The following is a description of a gene set: Mouse Gene Set: CUI_T_CELL_GD_IL1A_RESPONSE_UP studied in species Mus musculus Genes positively differentially expressed in cell type: γδ T cell upon treatment with cytokine: IL-1α in mouse lymph nodes in vivo. Cytokines mediate cell-cell communication in the immune system and represent important therapeutic targets. A myriad of studies have highlighted their central role in immune function, yet we lack a global view of the cellular responses of each immune cell type to each cytokine. To address this gap, the authors created the Immune Dictionary, a compendium of single-cell transcriptomic profiles of more than 17 immune cell types in response to each of 86 cytokines (>1,400 cytokine-cell type combinations) in mouse lymph nodes in vivo. A cytokine-centric view of the dictionary revealed that most cytokines induce highly cell-type-specific responses. For example, the inflammatory cytokine interleukin-1β induces distinct gene programmes in almost every cell type. A cell-type-centric view of the dictionary identified more than 66 cytokine-driven cellular polarization states across immune cell types, including previously uncharacterized states such as an interleukin-18-induced polyfunctional natural killer cell state. from publication Cui A, Huang T, Li S, Ma A, Pérez JL, Sander C, Keskin DB, Wu CJ, Fraenkel E, Hacohen N (PMID 38057668), and this is the list of marker genes: Psmc1, Smyd2, Rrp9, Cmas, Isy1, Tmed2, Eef2, Psmd7, Il2ra, Ahsa1, Bzw1, Calr, Ube2n, Tardbp, Snrpa, Satb1, Bud23, Ptma, Srgn, Vcp, Dnajc2, Sdc4, Hnrnph2, Lyar, Psme1, Hcls1, Eif3g, Ddx56, Psmd1, Il17a, Sdad1, Utp20, Timm13, Glrx3, G3bp1 (NCBI Gene Id 97760), Samsn1, Pon2, Dad1, Smap2, Mrto4 (mRNA turnover 4, ribosome maturation factor), Ddit4, Gzmb, Etf1, Ccdc184, Kdelr2, Acot7, Fam107b, Cct3, Psmd2, Wdr12, Uqcc4, Apobec3, Slc16a1, Stt3b, Atp5mc1, Dus2, Hyou1, Rsl1d1, Got2, Lpcat1, Traf1, Atad3a, Nop10, Ttc39b, Slc1a5, Cct8, Glrx5 (NCBI Gene Id 73046), Noc3l, Pgam1, Ly6a, Ndufab1, Ccr4, Mars1, Gzmc, Stx6, Timm9, Actg1, Ruvbl1, Atxn2l, Aen, Mbd3, Mettl1 (NCBI Gene Id 70215), Mllt6, Atf4 (activating transcription factor 4), Sec61b, Serp1, Llph, Abce1, Surf4, M6pr, Dctpp1, Polr2f, Cycs, Niban1, Tmed10, Orai1, Nars1 (NCBI Gene Id 98111), Lad1, Pdcd1lg2, Igfbp4, Prmt3, Hnrnpa3, Rel, Eif3d, Il17f (interleukin 17F), Ppp1r14b, Cct5, Tnfaip8, Rrs1, Smarcc1 (SWI/SNF related, matrix associated, actin dependent regulator of chromatin, subfamily c, member 1), Yrdc, Lsm6, Tomm20, Hif1a, Npnt, Arap2, Mrpl36, Cyb5b, Zmiz2, Rab8b, Cd72, Nudc, Slc25a5, Ppa1, Ubqln4, Scfd1, Eif4a3, Prps1, Higd1a, Ddx10, Stip1, Pwp1, Ppan, Phip, Pcyt1a, Nip7, Atp5mc3, Rpn1, Eif3a, Ppp1r14c, P4hb, Hmgn3, Txn2, Caprin1, Tfrc (transferrin receptor), Emc6, Wdr75, Pcbp1, Hnrnpab, Sin3b, Ipo4, Dennd4a, Ncoa7, Ybx3, Eif3c, Txndc17, Ifrd2, Atic, Thumpd3, Batf, Bcl2a1d, Gar1, Hsp90b1, Morf4l2, Stat5a (signal transducer and activator of transcription 5A), Phb2, Ssr4, Pa2g4, Banf1, Uck2, Nfkbia, Srm, Uqcrq, Hsd17b12, Tmed9, Emc4, Fubp1, Tomm70a, Spcs3, Dus1l, Tomm5, Dnajb11, Mat2a, Pabpc1, Bcl2l1, St13, Birc3, Hint1, Irf5, Ssr2, Furin, Sars1, Serpinb9, Ranbp1, Nadk, Hspa9, Ndufb6, Ivns1abp, Cluh, Rars1, Zeb2, Bysl, Timm8a1, Lman2 (NCBI Gene Id 68561), Ppme1 (protein phosphatase methylesterase 1), Med11 (mediator complex subunit 11), Cmss1, Wnk1, Tuba1c, Wdr77, Ltv1, Ftsj3, Pomp, Mir155hg, Eef1g, Cytip, Fam162a, Pebp1, Il22, Tubb4b, Sec14l1, Psmb2, Mecr, Prelid3b, Snrpd2, Cdc37, Ddost, Gnl3, Ptbp1, Srp72, Hspa5, Crem (cAMP responsive element modulator), Slc25a3, Rras2, Psmb6 (NCBI Gene Id 19175), Set, Hsp90aa1, Gtpbp4, Tex2, Dkc1, Anp32a, Hsp90ab1, Snx18, Prmt1, Hat1, Nap1l1, Rcc2, Eprs1, Prdx6, Rbm25, Bcl3, Gspt1, Hprt1, Kdm2b, Nudt21, Hdlbp, Mthfd1l, Ebna1bp2, Prdx1, Marcks, U2af1, Cblb (NCBI Gene Id 208650), Xbp1, Kars1, Ywhaq, Cish, Aprt, Slc35b1, Tmem147, Ifitm2, Herpud1, Cacybp, Odc1, Nop2, Syncrip, Serpinb6b, Ahr, Relb, Sytl3, Cebpz, Farsb, Srsf2, B4galnt1, Hnrnpa1, Comtd1, Cd83, Polr1d, Eif3i, Hspa4, Psmg3, Npm1, Ikbke, Cysltr2, Phf5a, Gmps, Ccdc124, Sfxn1, Tmed5, Prr29, Nhp2, Nifk, Mvp, Adam8, Naga, Kpnb1, Spcs2, Mrpl20, Ipo7, Bzw2, Pou2f2 (POU domain, class 2, transcription factor 2), C1qbp, Mybbp1a, Snrpb, Nfkb2, Pdia6, Larp1, Gsto1, Psmc5, Psma3, Erh, Manf, Timm10, Snrpf, Socs3, Entr1, Serbp1, Pim2, Atf5, Fam120a, Noc2l, Npm3, Nop16, Impdh2, Sms, Hspe1, Ehd1, Snrpa1, Hnrnpd, Ythdf2, Stat3, Gars1, Psma5, Gpr18, Nup62, Eftud2, Slc15a3, Eif1ax, Wdr43, Ybx1, Ahcyl2, Trp53, Denr, Mrpl12, Ptp4a2, Nme1, Ecd, Smox, Atp2a2, Chmp4b, Atp1a1, Uchl5, Lap3, Map2k3, Pus7, Ddb1, Mdn1, Umps, Iars1, Fabp5, Ddx21, Rsl24d1, Nolc1, Tomm40, Azin1, Srsf3, Zeb1, Btf3, Bcap29 (B cell receptor associated protein 29), Canx, Slc19a1, Tmem154 (NCBI Gene Id 320782), Sar1a, Tkt, Mrpl17, Ipo5, Ube2i, Nap1l4, Rora, Nsun2, Srp9, Cks2, Rbpj, Phb1, Eif5a, Tsr1, Cnbp, Mapkapk2, Epop, Snrpd1, Wdr18, Macir (macrophage immunometabolism regulator), Atp5pb, Vars1, Bhlhe40, Ddx54, Eif2s2, Shmt2, Eif4g1, Il2rb, Tnip1, Nrip1, Tnfrsf9, Tars1 (NCBI Gene Id 28002), Pals2, Strap, Hdgf, Mrps6, Pdcd5, Hspd1, Irgm1, Ran, Atp2b4, Nudcd2, Pdcd1, Pitrm1, Rilpl2, Stx11, Eif4a1, Psma6, Creld2, Stoml2, Fbl, Myo1g, Ndufa12, Icam1, Tnfrsf18, Marcksl1, Dph3, Sdhaf1, Aars1, Snhg6, Abcc1, Ncl, Tcp1, Rrp15, Zfp593, Srsf9, Apex1, Cox7b, Snu13, Slc7a1, Cars1, Tmem248, Taf1d, Eif3b, Atp5f1d, Eif6, Gpatch4, Ern1, Aebp2, Kdm6b, Cyba, Ldha, Cox5a, Lsm12, Litaf, Nop56, Atp5f1b, Ptges3, Ccdc86 (NCBI Gene Id 74079), St6galnac4 (ST6 (alpha-N-acetyl-neuraminyl-2,3-beta-galactosyl-1,3)-N-acetylgalactosaminide alpha-2,6-sialyltransferase 4), Bcl2a1b, Nfkb1, Srsf7, Psmb5, Dcun1d5, Sdf2l1, Pum3, Dennd5a, Tma16, Tesk1, Gapdh, Kcnq1ot1, Sf3b3 (splicing factor 3b, subunit 3), Wars1, Dgat1, Wdr46, Txn1, Bax, Nop58 (NOP58 ribonucleoprotein), Psme3, Cct2, Gadd45b, Rbm3, Nfkbib, Mif, Cd82, Pdap1, Cpsf2, Txnl4a, Selenos, Hilpda, Tspan3, Naa20, Agpat4 (NCBI Gene Id 68262), Eif1, Ptpn22, Alkbh1, Eif1a, Tufm, Jak2, Slc39a7, Mydgf, Bcl2l11, Mthfd2, Hspa8, Ube2l3, Gjb2, Ddx39a, Ppp1cc, Polr2h, Laptm4b, Krtcap2, Zc3h12a, Fam110a, Utp11, Prpf40a, Sumo2, Rcl1, Psme2, Psma7, H13, Pabpc4, Rangap1, Pes1, Ddx1, Cdk4, Utp3, Cdv3